Given this list of marker genes Patl1, Cnot10, Cnot6l, Cnot4, Cnot3, Tnks1bp1, Cnot11, Zfp36, Cnot7, Cnot9, Cpeb3, Cnot1, Cnot8, Cnot6, Tob1, Cnot2, here is a description of the gene set: Mouse Gene Set: GOCC_CCR4_NOT_COMPLEX The Ccr4-Not complex is an eukaryotically conserved deadenylase that can initiate cytoplasmic mRNA decay, and reduce translation by releasing poly(A)-binding protein (Pab1/PABPC1). Ccr4-Not contains seven core subunits, including two poly(A)-specific exonucleases, Ccr4/CNOT6/CNOT6L and Caf1/Pop2/CNOT7/CNOT8. studied in species Mus musculus